Given this list of marker genes St6galnac1, Nlrp6, Cx3cr1, Napepld, Muc2, Card9, Nod2, Sprr2a1, Epg5, Lrrc19, here is a description of the gene set: The biological process involved in maintaining the steady-state number of cells within a population of free-living cells such as the bacteria in the gut. Mouse Gene Set: GOBP_HOST_MEDIATED_REGULATION_OF_INTESTINAL_MICROBIOTA_COMPOSITION studied in species Mus musculus